Given this list of marker genes ERC2, CCR1, ATE1, RASL10A, IGF2, ARHGEF7, WDR4, RAD51AP1, TMEM119, SPDEF, MATCAP2, EGR2, CENPO, TUBG2, MMP8, PPT2, KDF1, ATL1, PIM2, CEACAM20, CNIH2, CADPS2, DYDC1, MCM2, NSUN5, RASGRF2, FRMD3, SHISA6, MSANTD1, SLC22A13, CHL1, SNRPC, IGHMBP2, PRM2, PDGFRL, GPR143, DNAJB11, TMEM163, VASH1, SCAMP3, MAGED2, PI16, BLNK, ABCC2, BTBD3, CLTC, MEIKIN, RNASE1, CTHRC1, ITGA10, GSG1L, MOV10L1, BAIAP2, HSPA4L, CCL11, DOCK1, ANKZF1, LGI3, ANXA10, MREG, PPFIA3, MCF2L, TRPC5, SPIRE1, CLCA4, SMTNL1, B9D1, ADAMTS6, JAKMIP2, LRRC73, DDX23, SBSPON, STOML2, HACE1, LAMP5, NXF3, DUSP1, ATPAF2, TIMP3, OGFOD1, IRF4, MYH8, BMP15, GPAT4 (NCBI Gene Id 574440), EPHB2, TMC1, TAFA3, CXCL10, KIF6, WSB2, CYP17A1, COL11A1, SLC18A1, IRF9, PRR11, MYB, CTLA4, ACTR3B, HYOU1, MYLK (NCBI Gene Id 50483), PCSK9, PIK3R3 (phosphoinositide-3-kinase regulatory subunit 3), OR5P3, CHI3L1, DEFB119, SLC5A1, HSPA12A, HPX, TTK, STARD8, KIF2C, NEK5, ARPIN, MORN5, THEM5, HINT2 (histidine triad nucleotide binding protein 2), ADRA2A, GRM3, RPL3L, SLC12A8, ADAMTS2, HOXC10, POLE2, REL, TOGARAM2, FGF9, LPCAT2, CPNE5, NAPB, CACNG8, BYSL, PTPN20 (protein tyrosine phosphatase non-receptor type 20), ACAT2, OTC, MYO19, AMPD1, LHFPL6, NETO2, GKN1, SPRY1, SPC25, STXBP5L (NCBI Gene Id 9515), MARCHF9, SYCE1L, TNNI3K, HTT, PPP1R1B, ERN2 (NCBI Gene Id 388226), RAG2, PLXNA4, NIPSNAP3B, SYCP1, DSG1, PARP16, KPLCE, ISYNA1, TRIM9, RORC, ACCSL, TOX3, CFAP53, GNPTAB, CALCB, RFX4, VNN2, RND1, NR4A1, VEGFC (vascular endothelial growth factor C), SOX2, HOXA4, CYP3A7, OSGEPL1, LONRF1, TAFA2, FMO5, BACE2, PCDHB16, BCCIP, PDF, KLHDC10, DCSTAMP, ADGRF1, DHX58, RBBP5, ARFGEF3, SLC17A6 (NCBI Gene Id 57084), SPC24, CD69, CHMP4C, SLC1A4, MYOM2, C16orf87, ANKUB1, FAM181A, TERB1, CCL22, DNAAF8, GPR15, here is a description of the gene set: from publication Kaji T, Ishige A, Hikida M, Taka J, Hijikata A, Kubo M, Nagashima T, Takahashi Y, Kurosaki T, Okada M, Ohara O, Rajewsky K, Takemori T (PMID 23027924) To obtain insight into the genetic basis of the increase of functional activity of memory B cells over time, we compared the gene expression profiles of day 7 and day 40 NP-specific/IgG1 memory B cells, GC B cells and plasma cells in immunized WT mice and naïve B cells, before and after activation in vitro. studied in species Homo sapiens Human Gene Set: GSE11961_PLASMA_CELL_DAY7_VS_MEMORY_BCELL_DAY40_DN Genes down-regulated in day 7 plasma cells versus day 40 memory B cells.